The following is a description of a gene set: species: Mus musculus The non-covalent aggregation and arrangement of proteins and lipids to form a high-density lipoprotein particle. Mouse Gene Set: GOBP_HIGH_DENSITY_LIPOPROTEIN_PARTICLE_ASSEMBLY, and this is the list of marker genes: Apoa1, Apom, Apoe, Lcat, Abca7, Abca1, Nr1h2, Apoa2